The following is a description of a gene set: species: Homo sapiens Enables the transfer of a solute or solutes from one side of a membrane to the other according to the reaction: sugar(out) + cation(out) = sugar(in) + cation(in). Human Gene Set: GOMF_CARBOHYDRATE_MONOATOMIC_CATION_SYMPORTER_ACTIVITY, and this is the list of marker genes: SLC45A4, SLC45A1, SLC17A5, SLC5A10, SLC23A1, SLC5A11, SLC23A2, SLC5A9, SLC5A1, SLC45A3, SLC5A3 (solute carrier family 5 member 3), SLC2A9, SLC45A2, SLC5A2, SLC5A4, SLC2A10